The following is a description of a gene set: from publication Elo LL, Järvenpää H, Tuomela S, Raghav S, Ahlfors H, Laurila K, Gupta B, Lund RJ, Tahvanainen J, Hawkins RD, Oresic M, Lähdesmäki H, Rasool O, Rao KV, Aittokallio T, Lahesmaa R (PMID 20620947) The aim of this dataset was to study in detail the transcription kinetics initiated by cytokine IL-4 in early differentiation of Th2 cells. studied in species Homo sapiens Genes up-regulated in comparison of untreated CD4 T cells at 0 h versus the cells treated with IL4 and anti-IL12 at 4 h. Human Gene Set: GSE17974_CTRL_VS_ACT_IL4_AND_ANTI_IL12_4H_CD4_TCELL_UP, and this is the list of marker genes: SUSD4, FHIT, BBS9, MT1G, CES5A, SAMHD1, ITGA4, TRADD, OXNAD1, GABBR1, NAAA, ADAMTS5, MYO1G, HAR1A, SIK1, GCM1, STMN3, GRAMD1B, FAM204A, RP9P, ATXN1L, ST7L, LMO7, TBC1D5, PTPRM, MXD1, H1-10, TAGLN2, H2AC25, RNF139, SC5D, RFX3, ENPP2, SMYD3, TTN, FAM228B, DDIT4, PDE4D, TTC28, LCOR (ligand dependent nuclear receptor corepressor), BIN1, ENC1, SCARNA17, TNFRSF8, PTPRB, SYNM, TSPYL4, ORC4, BIN2, TPP1, TPD52, FAM111A, CCDC141, ASAH1, TCEA3, FAF1, SUCLG2, SNN, SLC10A7, ZFP36L2, ST3GAL5, HAUS5, TMEM132B (transmembrane protein 132B), TREM2, CRYL1, ITPRIP, TNRC6B, C11orf21, MYH11, H1-2, IRS2, EFHC2, DTD1, MPP7, EXT1, LY9, SLC7A7, LPP, CITED2, RCSD1, HSD17B11, AIG1, NSMCE3, G0S2, TDRD3, SP140L, TSC22D3, ZNF34, GPHN, PTS, ERP27, PRKCA, ARRDC3, ZNF731P, PSTK (NCBI Gene Id 118672), BRWD1, TIGD1, AK5 (NCBI Gene Id 26289), FBXL16, FRG1JP, RGS1, ZNF101, IQGAP2, PCSK5, SLC2A3, S100A6, EPHX2, TJP2, COMMD9, GPRASP2, DHRS13, IL36RN, ZIM2, REC8, GADD45A, MAFF, HYKK, PELI2, JUN, TGM7, ENSG00000280119 (NCBI Gene Id 650036), DPEP2, TOB1, PCIF1, PTP4A1, ISG20, ZNF831, DSC1, ATP2B1-AS1, PRKCB, C4BPA, DIS3L2, PGLS, NDRG1, EPHA4, LIMD1, SMIM10L1 (NCBI Gene Id 100129361), ARHGEF11, PARP8, IRF2BP2, PCNT, SNX29, MEF2D, SNCAIP (NCBI Gene Id 9627), PRUNE2, SGTB, GPATCH2, SLC22A18, TARBP1, PTGS2, OGFRL1, SUGT1P3, DUSP1, ANKRD36C, KCNA3, DNAJB1, BMX, UBASH3B, CGRRF1, SMIM31, RHEBL1, FBXL12, PYHIN1, KAT6B, EIF4E3, KLF11, CKAP2, STK16, HAUS3, SKAP1, RBM33, ZDHHC11, PIGA, ACAP1, LYRM9, ALDOC, RAP1GAP2 (NCBI Gene Id 388321), SLC9A9, TPM2, MXI1, MARCHF2, KIFC2, TTC32, ZC3HAV1, ADGRE1, VNN2, DIAPH2, SLC22A23, CDADC1, GADD45B, PLAC8, FAM8A1, PPP3CC, PNPLA7